Given this list of marker genes ITGB1, ADCY9, GNB4, GNG2, GNG4, SRC, GNG3, PRKAR2B, ADCY1, GPER1, ADCY7, ADCY6, GNGT2, GNAI3, GNGT1, GNB2, GNAZ, GNAT3, ADCY2, ITGA5, GNG10, PRKACG, PRKAR1A, PRKAR1B, SHC1, ADCY8, ADCY5, PRKAR2A, GNG13, GNG12, FN1, GNG5, GNB5, GNB1, GNAI2, GNG8, GNG7, GNB3, GNAS, ADCY4, GNAI1, GNG11, PRKACA, ADCY3, PRKACB, here is a description of the gene set: species: Homo sapiens Human Gene Set: REACTOME_GPER1_SIGNALING GPER1 signaling